Given this list of marker genes TLR6, TRAF3, CD300LF, TICAM2, IRF3, IKBKB, MAP3K7, CD274, TRAF6, TICAM1, TLR4, here is a description of the gene set: species: Homo sapiens The series of molecular signals initiated by a ligand binding to a toll-like receptor where the TRIF adaptor mediates transduction of the signal. Toll-like receptors directly bind pattern motifs from a variety of microbial sources to initiate an innate immune response. Human Gene Set: GOBP_TRIF_DEPENDENT_TOLL_LIKE_RECEPTOR_SIGNALING_PATHWAY